Given this list of marker genes KLF5, ARG1, HMOX1, BTG2, RGS2, EEF1A2, BIK (NCBI Gene Id 638), EXTL2, PTX3, SECTM1, TRIB1, TRGC1, SERTAD2, SOD2, BTG1, LST1, SERPINF1, SPINT2, CA2, SERPINI1 (NCBI Gene Id 5274), MLC1, KCNMB1, PTPRC, C3AR1, KIAA0513, GLIPR1, RAB31, IL1RN, CCND2, GBP1, CXCR4, CD7, TRDC, S100A9, HCAR3, ARC, BCL2A1, DYNLT3, ARHGEF5, AKAP12, GGH (gamma-glutamyl hydrolase), ACSL1, GCH1, NFIL3 (NCBI Gene Id 4783), PTPN3 (NCBI Gene Id 5774), TANK, ANXA1, LITAF, FIG4, ID2, VCL, here is a description of the gene set: from publication Tavor S, Park DJ, Gery S, Vuong PT, Gombart AF, Koeffler HP (PMID 14517214) Genes up-regulated in KCL22 cells (chronic myelogenous leukemia, CML, with BCR-ABL1 fusion) by expression of CEBPA. Human Gene Set: TAVOR_CEBPA_TARGETS_UP species: Homo sapiens The transcription factor C/EBPalpha plays a critical role in the process of granulocytic differentiation. Recently, mutations that abrogated transcriptional activation of C/EBPalpha were detected in acute myeloid leukemia patient samples. Moreover, the progression of chronic myelogenous leukemia (CML) to blast crisis in patients was correlated with down-modulation of C/EBPalpha. The KCL22 cell line, derived from BCR-ABL+ CML in blast crisis, expressed wild-type C/EBPepsilon protein but not a functional C/EBPalpha, -beta, and -gamma. Restoration of C/EBPalpha expression in KCL22 cells triggered a profound proliferative arrest, a block in the G2/M phase of the cell cycle and a gradual increase in apoptosis. Within 3 days of inducing expression of C/EBPalpha, a remarkable neutrophilic differentiation of the KCL22 blast cells occurred as shown by morphologic changes, induction of expression of CD11b, primary, secondary, and tertiary granule proteins, and granulocyte colony-stimulating factor receptor. Using high density oligonucleotide microarrays, the gene expression profile of KCL22 cells stably transfected with C/EBPalpha was compared with that of empty vector, and we identified genes not previously known to be regulated by C/EBPalpha. These included the up-regulation of those genes important for regulation of hematopoietic stem cell homing, granulocytic differentiation, and cell cycle, whereas down-regulation occurred for genes coding for signaling molecules and transcription factors that are implicated in regulation of proliferation and differentiation of hematopoietic cells. Our study showed that restoration of C/EBPalpha expression in BCR-ABL+ leukemic cells in blast crisis is sufficient for rapid neutrophil differentiation suggesting a potential therapeutic role for ectopic transfer of C/EBPalpha in acute phase of CML.